The following is a description of a gene set: Human Gene Set: GSE21033_CTRL_VS_POLYIC_STIM_DC_6H_DN Genes down-regulated in bone marrow-derived dendritic cellstreated by poly(IC): 0h versus 6h. BACKGROUND: Dendritic cells (DC) play a central role in primary immune responses and become potent stimulators of the adaptive immune response after undergoing the critical process of maturation. Understanding the dynamics of DC maturation would provide key insights into this important process. Time course microarray experiments can provide unique insights into DC maturation dynamics. Replicate experiments are necessary to address the issues of experimental and biological variability. Statistical methods and averaging are often used to identify significant signals. Here a novel strategy for filtering of replicate time course microarray data, which identifies consistent signals between the replicates, is presented and applied to a DC time course microarray experiment. RESULTS: The temporal dynamics of DC maturation were studied by stimulating DC with poly(I:C) and following gene expression at 5 time points from 1 to 24 hours. The novel filtering strategy uses standard statistical and fold change techniques, along with the consistency of replicate temporal profiles, to identify those differentially expressed genes that were consistent in two biological replicate experiments. To address the issue of cluster reproducibility a consensus clustering method, which identifies clusters of genes whose expression varies consistently between replicates, was also developed and applied. Analysis of the resulting clusters revealed many known and novel characteristics of DC maturation, such as the up-regulation of specific immune response pathways. Intriguingly, more genes were down-regulated than up-regulated. Results identify a more comprehensive program of down-regulation, including many genes involved in protein synthesis, metabolism, and housekeeping needed for maintenance of cellular integrity and metabolism. CONCLUSIONS: The new filtering strategy emphasizes the importance of consistent and reproducible results when analyzing microarray data and utilizes consistency between replicate experiments as a criterion in both feature selection and clustering, without averaging or otherwise combining replicate data. Observation of a significant down-regulation program during DC maturation indicates that DC are preparing for cell death and provides a path to better understand the process. This new filtering strategy can be adapted for use in analyzing other large-scale time course data sets with replicates. studied in species Homo sapiens from publication Olex AL, Hiltbold EM, Leng X, Fetrow JS (PMID 20682054), and this is the list of marker genes: WNT5B (Wnt family member 5B), KDM3B, TBC1D10C, CES2, AMHR2, IL2RA, FAM168B, HIPK4, NKPD1, INSYN2B, AZI2, PARVB, HIVEP2, R3HDM1, AANAT, TNIP1, KLF3, ADAMTSL2, WDFY2, ANGPTL1, LYST, DNAJC6, OSBP, NRIP2, ZC2HC1A (NCBI Gene Id 51101), VAMP1, F13A1, MBNL2, SYNE1, TTPAL, FAM53B, MIR455, GTF3C2, GAS2L1, KDM5A, KAT6B, LTB4R2, DDX46, SPG11, PIAS2, USP25, KDM5B, TRPV6, FUT8, CREBBP, BRAF, LRIG1, AP3M2, FCHO2, YPEL5, LCP2, C1orf50, CCN6, FBXL17, KLHL7, IL1A, ANGPT2, NPAS2, GPR150, RREB1 (NCBI Gene Id 6239), BDP1, BTBD7, AFTPH, ZFYVE26, LEAP2, FLVCR2, VAV2, SYN3, AFF1, NR1H5P, R3HDM2 (NCBI Gene Id 51220), IKZF3, ARID2, TNRC6A, FAM24A, CLEC9A, BPIFC, CDK13, S100A14, KLK10, SKIL, TAPBPL, CCL3, WDR27, SLC6A11, SMARCA4, SSX9P, OTUD3, ASXL2, TRAPPC9 (trafficking protein particle complex subunit 9), FNBP4, ZNRF1, OGT, SYNJ1, CDC37L1, ATP2C1, SUPT7L, GPS2, SNX19, STRIP1, AXIN1, MIGA1, H6PD, CD2AP, CAV3, FMNL2, CHST5, C2CD3, RAB5A, PGBD1, KLHL8, FRMD7, IGFN1, MICU3, PDPK1, ITPR1, PI4K2A, ARFGEF2, KREMEN1, MEGF8, IP6K2, PRKDC, TMEM131, ITGAL, DOCK2, DENND1B, SLTM, DUSP7, AMIGO3, SEMA7A, DENND1A, MYLK3, PRRC2C, MIR449C, GGCX, SH3KBP1, PARP8, APLNR, PPFIBP2, COG1, ATXN7L1, KMO, CD164, KMT2D, B3GALT2, ORM1, URB2, TBC1D2B, MYLIP, C3orf22, GGN, HSPB3, DICER1, TGM5, STIM2, EID3, RPRD2